Given this list of marker genes Adamtsl2, Polr2a, Adamtsl5 (NCBI Gene Id 66548), Ltbp2, Ltbp1, Vwa1, here is a description of the gene set: species: Mus musculus Mouse Gene Set: GOMF_MICROFIBRIL_BINDING Binding to a microfibril, any small fibril occurring in biological material.